The following is a description of a gene set: species: Mus musculus The developmental growth that results in the elongation of the rostral-caudal axis that contributes to somitogenesis. Mouse Gene Set: GOBP_AXIS_ELONGATION_INVOLVED_IN_SOMITOGENESIS, and this is the list of marker genes: Lrp6, Ppp2r3a, Sfrp1, Med12, Wnt3a (NCBI Gene Id 22416)